The following is a description of a gene set: Wilms tumor is one of the most frequent neoplasias in children. Our previous microarray screening in a large series of Wilms tumors revealed several candidate genes that are deregulated in advanced tumors and are part of the retinoic acid signaling pathway. To investigate whether retinoic acid could be employed as a novel therapeutic agent in these tumors, we treated cultured Wilms tumor cells with different concentrations of all-trans retinoic acid (ATRA) and assessed gene expression changes by real-time RT-PCR as well as microarray analysis. Several genes like RARRES1, RARRES3, CTGF, CKS2, CCNA2, IGFBP3, UBE2C, CCL2 or ITM2B that were previously found to be deregulated in advanced tumors exhibited opposite expression changes after ATRA treatment. In addition to enhanced retinoid signaling, the transforming growth factor-beta (TGFbeta) pathway was strongly activated by ATRA treatment of Wilms tumor cells. Both the retinoic acid and the TGFbeta pathway mediate inhibition of cell growth. These findings represent the first molecular evidence of a potential benefit from ATRA treatment in Wilms tumors. species: Homo sapiens Genes down-regulated in MZ128 cells (Wilms tumor with mutated WT1) after treatment with 10 microM tretinoin (ATRA) for 24 h. Human Gene Set: ZIRN_TRETINOIN_RESPONSE_WT1_DN from publication Zirn B, Samans B, Spangenberg C, Graf N, Eilers M, Gessler M (PMID 15897880), and this is the list of marker genes: TLR5 (NCBI Gene Id 95519), AQP1, KRBOX4, TYSND1, SCAF11, ECE1